The following is a description of a gene set: Human Gene Set: GOMF_AROMATIC_AMINO_ACID_TRANSMEMBRANE_TRANSPORTER_ACTIVITY studied in species Homo sapiens Enables the transfer of aromatic amino acids from one side of a membrane to the other. Aromatic amino acids have an aromatic ring., and this is the list of marker genes: SLC3A2, SLC7A5, SLC43A2 (solute carrier family 43 member 2, NCBI Gene Id 124935), SLC38A5, SLC6A14, SLC15A4, SLC36A4, SLC38A3, SLC66A1, SLC16A10, SLC7A1